The following is a description of a gene set: Human Gene Set: HP_CEREBRAL_ARTERIOVENOUS_MALFORMATION An anomalous configuration of blood vessels that shunts arterial blood directly into veins without passing through the capillaries and that is located in the brain. species: Homo sapiens Cerebral arteriovenous malformation, and this is the list of marker genes: ENG, ACVRL1, GDF2, RASA1, KRAS, EPHB4, IL6, SMAD4